Given this list of marker genes Trp73, Ppp1r13b, Pou4f2, Ppp1r13l, Banp, Trp53 (transformation related protein 53), Phf20 (NCBI Gene Id 228829), Zfp385a, Trp63, here is a description of the gene set: electronically inferred by orthology from the curated human pathway This event has been computationally inferred from an event that has been demonstrated in another species.<p>The inference is based on the homology mapping from PANTHER. Briefly, reactions for which all involved PhysicalEntities (in input, output and catalyst) have a mapped orthologue/paralogue (for complexes at least 75% of components must have a mapping) are inferred to the other species. part of: Regulation of TP53 Activity studied in species Mus musculus Reactome Pathway: Regulation of TP53 Activity through Association with Co-factors